The following is a description of a gene set: Catalysis of the reaction: thioredoxin-dithiol + NADP+ = thioredoxin-disulfide + H+ + NADPH. species: Homo sapiens Human Gene Set: GOMF_THIOREDOXIN_DISULFIDE_REDUCTASE_NADPH_ACTIVITY, and this is the list of marker genes: TXNRD1, TXNRD2, TXNDC2, TXNRD3, TXN, NXN, SELENOT